The following is a description of a gene set: GnRH-GnRHR-PLCB-PKC signaling pathway. Pathway ID: N00873. Pathway type: Reference. Pathway class: nt06323 KISS1-GnRH-LH/FSH-E2 signaling. studied in species Homo sapiens Pathway Definition from KEGG: GNRH1/2 -> GNRHR -> (GNAQ,GNA11) -> PLCB -> (Ca2+,DAG) -> PKC -> RAF1 -> MEK -> ERK -> ELK1 => (LHB,CGA,FSHB) Human Gene Set: KEGG_MEDICUS_REFERENCE_GNRH_GNRHR_PLCB_PKC_SIGNALING_PATHWAY, and this is the list of marker genes: GNRH1, MAP2K1, PLCB2 (NCBI Gene Id 5330), GNAQ, PRKCA, GNRH2, MAPK3, RAF1, PRKCB, FSHB, GNA11, PLCB4, PLCB1, LHB, CGA, ELK1, GNRHR, PLCB3, PRKCG, MAPK1, MAP2K2